Given this list of marker genes Tspan5, Timp1, Sh3d19, Snx33, Timp3, Ptpn3, Tnfrsf1b, App, Il10, Tspan17, Timp4, Tnf, Rgma, Adra2a, Pacsin3, Snx9, Tspan15, Apoe, Adam9, Ifng, Il1b, Adam8, Lrig2, Nrdc, Timp2, Gpld1, here is a description of the gene set: Any process that modulates the frequency, rate or extent of the proteolytic cleavage of transmembrane proteins and release of their ectodomain (extracellular domain). studied in species Mus musculus Mouse Gene Set: GOBP_REGULATION_OF_MEMBRANE_PROTEIN_ECTODOMAIN_PROTEOLYSIS